Given this list of marker genes GNAO1, ADH5, CLEC10A, CALD1, CTDP1, MDP1, MRPL57, SCAF8, TPM1, DAB2, PSMA4, POU2F3, EIF4B, PMPCA, UBFD1, STK11, RPL8, RAB7A, RPS11, ABCD3, IPO9, SLC34A1, CKS1B, ATP2A1, YWHAG, ORMDL3, SLC32A1, GABBR1, COL1A2, NDUFB8, FZD8, SAP18, S100A6, KPNA1 (NCBI Gene Id 3836), RPS16, EIF2B3, RASA3, ARPP19, HIGD1A, C1QB, RPLP2, ASH2L, YBX1, PSMC5, AMD1, NEFM, HSPA8, ZC3H13, BRD3, HIF1A, GNAS, CCN1, NCS1, POLR1D, TARDBP, TOMM20, HSPH1, EVL, ANXA2, WWP2, RPL30, TNRC6A, NDUFS4, PCBP1, RPS5, B4GALT5, STX7, MOV10, HEBP1, FASLG, BRD4, NUDT5, MARCKS, RNASEH2A, PAQR7, NPC2, RPL35, FKBP3, SDHA, USP47, PSMA2, EZR, CLK2, TJP2, TUBB2B, CNN2, CRELD2 (NCBI Gene Id 79174), ANXA7, IFITM2, DPY30, EHD1, RPL19, SEC61B, AP1G2, TRIM28, PRDX5, RPS21, BRD2, CRABP2, RPL6, IL7R (NCBI Gene Id 3575), PTP4A2, ARPC3, RALY, ELAVL1, AK2 (adenylate kinase 2), EID1, CTCF, SNRPD2, DPP3, RPL27, FAU, MAPRE2, FKBP4, EIF3H, GLIPR2, UBE2K, RALBP1, POLR1C, HINT1, RPL28, CENPK, AKR1A1, SEC62, PSMG1, NFKBIA, ACTG1, HNRNPR, NPM1, RPS20, TEX10, NEDD8 (NCBI Gene Id 82917), PSPH, SRSF3 (serine and arginine rich splicing factor 3), PLOD1, WDR75, KRT4, RNF10, CYCS, PSMB4, EIF2S2, EIF4H, BEX3, WDR3, EIF4G2, LRRC17, FN1, KIF11, COX7A2, TPR, PPIA, TUBB4B, GFI1B, AGT, USP14, DAZAP1 (NCBI Gene Id 26528), BAG1, ADD2, SAMD4B, PIGF, AP3M1, UBXN1, DGCR6, SEPTIN7, KLHL17, PCNA, IPO5, SGPL1, SSB, HMGB2, RPL13A, ZMAT1, ENY2, PC, LOXL3, ABCF1, IER2, NUTF2, NUDCD2, IFITM1, SRSF7, CMTM5, ATP5PD, RPL14, BRD7, TES, ERGIC3, PNN, PKM, CDC42, CCND1, SMC1A, GAPDH, SPOUT1, COX4I1, PXK, RRAS2, HS6ST1, TRIR, CD63, ATP6V1C1, KRT19, SUPT5H, BTRC, SHROOM3, TAF3, MKRN1, VDAC3, RPL27A, STAT1, TXNDC9, MPDU1, PPAN, PRKAR1A, RPLP0, NUCKS1, KPNB1, POSTN, HSD17B4, GLUD1, LRIG1, PNP, CTSZ, RPL32, S100A14, GTF3A, PROS1, FAF1, PIK3CD, KIF20A, HNRNPAB, ARPC5, TUBA1B (NCBI Gene Id 88851), FKBP9, RPS7, SZRD1, PABPC1, DEDD, PER1, AAR2, UBA2, HSPA4, GFUS, LAMB1, EIF5B, TKT, ARHGEF12, NR3C1, RALGDS, EIF4G1, RPL21, CCT5, CAMK2G, COX7C, TMSB10, SYK, ATP5PB, STIP1, ENO1, SLC12A4, RPS15A, ATP5ME, RPS3, PCM1, KPNA2, ANTXR2, ANKFY1, ZNF780A, STRAP, RFC1, CLTA, PTTG1, NHP2, SKI, NCL, SLK, PLAC8, STAT5A, NDUFS2, KLF9, H2AZ1, PAF1, SPTBN1, CPSF2 (NCBI Gene Id 53981), H3-3B, CCT3, ARIH1, PSMD3, SSR3, SUB1, RPL7, COMMD3 (COMM domain containing 3), HDLBP, EGLN1, SSH1, DBI, RPL18A, KCMF1, NDUFC2, CD79A, TGFBI, HSPA5, PAK1, FASN, SERBP1 (SERPINE1 mRNA binding protein 1), PIP4K2A, NAP1L1, NFE2L2, FNBP4, HNRNPA2B1, ABHD8, ESPN (espin), ATP1A1, VCL, CDHR4, NKAPD1, NELFE, ABCE1, SMG1, VIM, MT1F, RPS8, ACADL, HNRNPU, GLUL, CDCA3, AIMP1, LAMC1, NDUFB7, RDX, ATP5F1A, RPL34, TUBB6 (NCBI Gene Id 84617), RPN1, WDR89, RPS6, ABCF3, PSMC2, AGPS, EIF3B, KIFAP3 (NCBI Gene Id 22920), HMGCS1, RPA2, CIRBP, SSNA1, IPO7, VDAC2 (voltage dependent anion channel 2), COX8A, DIO1, RPS14, PSMA7, PLCD1, DDX5, NACA (NCBI Gene Id 4666), HSP90B1, TACC3, EZH2, SMC5, RBM10, HSPE1, CCDC47, NDUFS6, UBE2Q1, CCT2, MAP3K12, CLEC4A (NCBI Gene Id 50856), CEND1, PEX13, RBX1, MTMR3, ACAT2, RPS29, U2AF2, BLOC1S1, APH1A, HSPD1, MAP1LC3B, DDX1, TUBB, GPN3, NCOR1, NF2, IFITM3, here is a description of the gene set: studied in species Mus musculus Human Gene Set: WANG_TUMOR_INVASIVENESS_UP Correlating tumor cell behavior in vivo with patterns of gene expression has led to new insights into the microenvironment of tumor cells in the primary tumor. Until now, these studies have been done with cell line-derived tumors. In the current study, we have analyzed, in polyoma middle T oncogene (PyMT)-derived mammary tumors, tumor cell behavior and gene expression patterns of the invasive subpopulation of tumor cells by multiphoton-based intravital imaging and microarray-based expression profiling, respectively. Our results indicate that the patterns of cell behavior that contribute to invasion and metastasis in the PyMT tumor are similar to those seen previously in rat MTLn3 cell line-derived mammary tumors. The invasive tumor cells collected from PyMT mouse mammary tumors, like their counterparts from rat xenograft mammary tumors, are a population that is relatively nondividing and nonapoptotic but chemotherapy resistant and chemotactic. Changes in the expression of genes that occur uniquely in the invasive subpopulation of tumor cells in the PyMT mammary tumors that fall on the Arp2/3 complex, capping protein and cofilin pathways show a pattern like that seen previously in invasive tumor cells from the MTLn3 cell line-derived tumors. These changes predict an enhanced activity of the cofilin pathway, and this was confirmed in isolated invasive PyMT tumor cells. We conclude that changes in gene expression and their related changes in cell behavior, which were identified in the invasive tumor cells of cell line-derived tumors, are conserved in the invasive tumor cells of PyMT-derived mouse mammary tumors, although these tumor types have different genetic origins. Up-regulated genes in the subpopulation of invasive PyMT cells (breast cancer) compared to the general population of PyMT cells. from publication Wang W, Wyckoff JB, Goswami S, Wang Y, Sidani M, Segall JE, Condeelis JS (PMID 17440055)